Given this list of marker genes Ankrd50, Exoc6b, Clstn1, Rab11a, Phaf1, Sec16a, Atp9a, Grip1, Cnst, Krt18, Cplx1, Rab34, Snap47, Vps51, Ank3, Hgs, Scrib, Vps13b, Fcgr2b (Fc receptor, IgG, low affinity IIb), Vamp5, Nsf, Rab17, Ehd1, Optn, Stx1b, Ehd4, Arhgap8, Rab11fip3, Pla2g4e, Mapk10, Nsg1, Kif13a (kinesin family member 13A), Rab31, Snx4, Akap5 (A kinase anchor protein 5), Washc1, Golga4, Acsl3, Ehd2 (EH-domain containing 2), Ptpn23, Csk, Bves, Arf6, Chic2, Rab14, Vamp4, Stx3 (NCBI Gene Id 20908), Snx12, Rab8a, Lrrc7, Arhgap1, Ehd3, Myo5b, Vps26a, Scarb2, Gga2, Ccdc93, Dennd1a, Amn, Llgl1, Sacm1l, Vps52, Acap2, Sys1, Commd1, Eipr1, Rab26, Exoc6, Rab13 (RAB13, member RAS oncogene family), Arl4c, Ankrd27, Rab8b, Golga7, Vamp2, Vps50, Entr1, Rab12, Vps35, Vps29, Gripap1, Camk2a, Snx3, Snf8, Rab35, Mylk, Snx31, Actn2, Inpp5f, Rab7, Vps26c, Bbs2, Mtmr4, Zdhhc2, Pkdcc, Trarg1, Arhgap44, Exoc4, Gga3, Pla2g3, Lyplal1, Snx30, Stx6, Dennd1c, Arfgef2, Stx4a, Atp6ap1, Sorl1, Exoc2, Slc1a1, Vps39, Gga1, Vps35l, Snap23, Arfrp1, Stx12, Grip2, Sptbn1, Rabep1, Dennd1b, Snx7, Bltp1, Epg5, Blzf1, Bbs1, Rab11fip4, Vps53, Lmtk2 (NCBI Gene Id 72890), Exoc5, Cmtm6, Epb41l1, Eps15, Stxbp5l, Dnm2, Llgl2, Snx17, Exoc8, Arl3, Ccdc22 (coiled-coil domain containing 22), Exoc1, Rab11b (RAB11B, member RAS oncogene family), Micall2, C2cd6 (C2 calcium dependent domain containing 6), Ndrg4, Cln3, Golph3, Def6, Vamp3, Steap2, Wipf3, Micall1, Snx27, Macf1, Atp2c1, Golph3l, Stx16, Prepl (NCBI Gene Id 77396), Rab10, Lypla1, Rack1, Vti1a, Stxbp5, here is a description of the gene set: The directed movement of substances to the plasma membrane in transport vesicles that fuse with the plasma membrane by exocytosis. studied in species Mus musculus Mouse Gene Set: GOBP_VESICLE_MEDIATED_TRANSPORT_TO_THE_PLASMA_MEMBRANE